The following is a description of a gene set: from publication Hale JS, Youngblood B, Latner DR, Mohammed AU, Ye L, Akondy RS, Wu T, Iyer SS, Ahmed R (PMID 23583644) Human Gene Set: GSE43863_NAIVE_VS_LY6C_LOW_CXCR5NEG_CD4_EFF_TCELL_D6_LCMV_UP CD4 T follicular helper (Tfh) cells provide the required signals to B cells for germinal center reactions that are necessary for longlived antibody responses. However, it remains unclear whether there are CD4+ memory T cells committed to the Tfh lineage after antigen clearance. Using adoptive transfer of antigen-specific memory CD4+ subpopulations (based on CXCR5 and Ly6c expression)in the LCMV infection model, we found that there are distinct memory CD4+ T cell populations with commitment to the Tfh and Th1 lineages. Our conclusions are based on gene expression profiles, epigenetic studies and phenotypic and functional analysis. The gene expression profiles of virus-specific CD4 T cell subets at effector and memory stages is presented here. species: Homo sapiens Genes up-regulated in CD4 SMARTA T cells: naïve versus Ly6c low CXCR5- effector during acute infection of LCMV., and this is the list of marker genes: H2AC6, CXCL2, ZNF765, LYPD4, SLC2A12, TTC21B, BCL6B, ODAM, PRKCSH, CYFIP2, NAV2-AS5, B4GALNT1, PNLDC1, C19orf48P, LHFPL3, LINC01968, PA2G4 (NCBI Gene Id 5036), HSPB6, LPP-AS2, EIF6, GBP6, FABP7 (NCBI Gene Id 2173), LNX1, GPR78, LRMDA, CST5, TREML5P, CIRBP, RFFL (NCBI Gene Id 117584), ICOSLG, PSMC1, C15orf48, COX4I1, ZBTB11-AS1, WNK3, ERICH6, RPL27A, RPL31, MT1E, SOX8, ATAD2B, ABCA5, S100A13, ZNF462, ZNF713, PRKCZ-AS1, GPR21, TEX36-AS1, ZNF580, EOLA1-DT, SPEN-AS1, DNPH1, KCNJ3, MMP28, LY6K, SDHAP2, IL17D, SGSM2, FCGR2C, CAPN5, RAD9A, PRELID3A, CD1C, ARHGEF2, SIX6, CEP83, ERLEC1P1, NFKB2, RHPN2 (rhophilin Rho GTPase binding protein 2), NOG, AMT, SNHG15, PISD, IGKC, PRKCQ, SCARNA15, BICC1, IL18R1 (NCBI Gene Id 8809), NDUFB8, REXO1L1P, BPESC1, NOD2, TMEM176A, SLC52A2, TCF12-DT, LRRK2, GRIN2D, ZNF786, TFAP2A, TFIP11, RALA, PRSS59P, ZNF202, DRC1, CROCCP2, ZNF141, AS3MT, G6PC2, BOLL, TDH, LINC00525, LINC00301, ATF3, ZNF488, CCL4 (NCBI Gene Id 6351), GRAP, ZNF10, MAT2A, CGA, SUGP1, IQUB, SLC22A9, SPRR4, CCNL2, ZXDC, ATP12A, TWNK, LENG8, AA06, MCAM (melanoma cell adhesion molecule), TNFAIP2 (NCBI Gene Id 7127), EIF4EBP1, POSTN (NCBI Gene Id 10631), TGFB3, NUDCD3, PPIAL4A, SNORA78, MIR17HG, LLCFC1, BGLAP, MAN2A2, HEXD, TCEANC2, CNDP1, CLASRP, SDHAP1, CXCL8, DNAL1, UBE2Q2P13, ASPHD1, KRTAP4-12, PTPDC1, TRIM45, CFAP157, BCHE, OPTN, CD209, LINC01270, C4BPA, SELE, PLA1A, LINC00523, TAS2R45, WDR81, COL27A1, ATG16L2, TRAPPC14 (trafficking protein particle complex subunit 14), SEC31B, GRK3, LINC01141, CCL2, SLC34A2, PMM2, S100B, SLC22A2, MOBP (myelin associated oligodendrocyte basic protein), C5, DNAAF1, DPH7, VCAM1, FAM9A, CXCL1, INPP4B, ZIM3, DCD, SF3B2, CLUHP3 (clustered mitochondria homolog pseudogene 3), LINC00269, NFKBIE, AVPR1B, MYLK4, TPSG1, A2M-AS1, MT1X, BMP10, CCL8, ANXA2P2, MGAT1, BCL2A1, BTG2-DT, JDP2, CD244 (CD244 molecule), MANBA